Given this list of marker genes Nus1, St6gal1, Gfpt1, Gnpnat1, Dolpp1, Slc17a5, Ctsa, St6galnac6, Cmas, Dhdds, Nanp, St8sia5, Nans (N-acetylneuraminic acid synthase (sialic acid synthase)), Slc35a1, Fpgt, Fuom, Glb1, Mpi, Pmm1, Srd5a3, Neu4, St6galnac5, St6galnac3, Slc35c1, Gmds, Dpm1, St6galnac4, Nagk, Uap1, St3gal3, Fcsk, Gmppb, St8sia4, Dpm3, Gne, Renbp, Pgm3, Neu2, Alg5, Npl, Alg8, Alg14, St3gal2, Pmm2, Neu1, Gfpt2, Amdhd2, St3gal4, Dpagt1, St8sia6, Alg9, Neu3, St8sia2, Mvd, St8sia3, St6galnac1, St3gal1, Glt28d2, Alg2, St6galnac2, St3gal6, Hk1, Gm20716, St6gal2, Mpdu1, Alg3, St8sia1, Alg1, Dpm2, Nudt14, St3gal5, Gfus, Alg6, Gmppa, Alg12, Dolk, here is a description of the gene set: Mouse Gene Set: REACTOME_BIOSYNTHESIS_OF_THE_N_GLYCAN_PRECURSOR_DOLICHOL_LIPID_LINKED_OLIGOSACCHARIDE_LLO_AND_TRANSFER_TO_A_NASCENT_PROTEIN studied in species Mus musculus Biosynthesis of the N-glycan precursor (dolichol lipid-linked oligosaccharide, LLO) and transfer to a nascent protein